Given this list of marker genes Dysf, Ppl, Hmgb1, F9, Tsku, Gata1, Rap2b, Ccn1, P2ry12, Hrg, Cd9, Scrib, Mfsd2b, Rreb1, Cd151, Prrg2 (NCBI Gene Id 70039), Anxa5, Gsdmd, Tor1a, Apoh, Duox2, Emilin1, Smad3, Fgl2, Insl3, Enpp4, Ccn4, Smoc2, Serpinf2, Papss2, Plek (NCBI Gene Id 69998), Mmrn1, Msx2, Pdcd10, Cd109, Prdx2, Tfpi2, Tmem97, Tfpi, Pdia3, Vtn, Tpm1, Gp1bb, Srsf6, Fermt1 (NCBI Gene Id 241639), Cldn1, Ext1, Clec7a, Epb41l4b, Gas6, Rhoa, Il1a, Pik3cb, Adra2a, Krt6a, Ddr2, Chmp7, F11r, Fntb, Gp1ba, Adra2b, Flna, Anxa1, Vil1, Plpp3, Hps1, Arhgef19, Lnpk, F12, Macf1, Pten, Fgl1, Mpig6b, Pecam1, Cxcr4, F11, Serpina10, Serpine1, Pdgfb, Gna13, Adamts18 (NCBI Gene Id 208936), Tspan8, Bloc1s6, Gp5, Ppara, Adipor2, Psg23, Fundc2, F10 (NCBI Gene Id 14058), Prrg1, Ppia, Gata4, Fgg, Fermt2, Kank1, Angptl1, Il6ra, Plau, Mtor, Vegfb, Hps4, Prss56, Ins2, Htr2a, Vangl2, Chmp4c, Jaml, Gnas (NCBI Gene Id 78290), Cd44, Cfh, Chmp3, Chmp1a, Fer1l5, Ppard, Ajuba, Chmp2b, Xbp1, Gnaq, Dag1, Fgf10, Celsr1, F5, Slc6a4 (solute carrier family 6 (neurotransmitter transporter, serotonin), member 4), Prkce, Chmp2a, Arl8b, F2rl2, Cnn2, Nf1, Emilin2, Mmp12, Ptk2, Smpd1, Igf1, Phldb2, Ubash3a, Vps4b, Chmp5, Thbd, Col3a1, Pdia2, Prrg4, Fcer1g, Trim72, Mrtfa (myocardin related transcription factor A), Fga, Tyro3, F13a1, Eng, Sdc4, Cldn13, Lrg1, Coro1b, Ccm2l, Plaur, S100a10, Hmox1, Dsp, Grhl3, Pros1 (protein S (alpha)), Syt11, Syt7, F2r, Chmp6, Map3k1, Bnc1, Ins1 (insulin I), Evl, Ptprj, Myh10, Mertk, Comp, Arhgap35, Ajap1, Cd36, Cdkn1a, Gpx1, Myh9, Hnf4a, Entpd2, Hgfac, Eppk1 (epiplakin 1), Mia3, Pdpn, Cpb2, Selp, Pdia4, Fbln1, Foxc2, Cav3, Tspan9, Cav1, Fgfr1op2, Cldn19, Foxa2, Casp7, Angptl4, Casp1, Mylk, Timp1, Wnt7a, Wnt3a, Alox15, Drd5, Plet1, Stxbp1, Ctsg, Angptl6, Hps5, Hras, Lrrc25, Itgb1, Gata2, Prkcd, Sytl4, Pard3, Angptl7, Rab3a, Tbxa2r, Cx3cl1, F8 (coagulation factor VIII), Nog, Vegfa, Vwf, Erbb2, Proc, Fgb, Prkg1, Rhoc, Ceacam1, Gpr4 (G protein-coupled receptor 4), S100a9, Dmtn, Axl, Prrg3, Srf, Stard13, Svep1, BC004004, Itga5, Cela2a, Fn1, Kng2, Evpl, Hbegf, Serping1 (serine (or cysteine) peptidase inhibitor, clade G, member 1), Nfe2l2, Dst, P2rx1, Ephb2, Ndnf, Muc16, Angpt2, Itgb5, F2, Ddr1, Cd40lg, Tec, Chmp4b, Entpd1, Bloc1s4, Clasp1, Ptpn6, Wnt5a, Acvrl1, Reg3a, Tpsab1, Itgav, Ptger4, Scnn1g, Pip5k1c, Notch2, Itgb3, Dcbld2, Crk, Pdia6, Cadm4, F13b, Kdr, Wfdc1, Yap1, Carmil2, Myoz1, Serpind1, Scnn1b, Fgf2, Arfgef1, Rasa3, Hif1a, Prf1, Angpt1, Mcam, Nbeal2, Lyn, Anxa8, Ccl2, Jak2, Lilrb4a, Tafa5, F2rl1, Plat, Gp9, Alox5 (NCBI Gene Id 232336), Plec, Slc11a1, Lyst, Pdgfa, Ubash3b, Nfatc1, Wnt4, Clasp2, Cask, Arhgap24, Fkbp10, Ano5, Aqp1, Fzd6, Nlrp6, Slc7a11, Tlr4, Anxa2, Shh, Pou2f3, Odam, Angptl2, Stxbp3, Col5a1, Tmprss6, P2ry1, Tubb1, Cldn4, Gzmb, Fermt3, Angpt4, Pf4, Rab27a, Duox1, Pear1, Ccr2, F3, Adra2c, Vkorc1, Nrg1, Nrp1, Serpinc1, Fzd7, Il6, Cxadr, Tnfrsf12a, Prkca, Itpr3, Apoe, Cd34, Actg1, Dtnbp1, Myof, Tspan32, Ptk7, Pak1, Slc12a2, Hps6, St3gal4, Snai2, Klkb1, Bloc1s3, Serpine2, Tgfb2, Fgf1, Pdgfra, C1qtnf1, Gla, Ano6, Elk3, Kng1, Adamts13, B4galt1, Prkcq, Reg3g, Adtrp, Pparg, Npr2, Tnf, Chmp1b2, Syk, Plg, Sh2b3, Hpse, Gp6, Prcp, Tmx1, Alox12, Proz, C1galt1c1, Clec10a, Thbs1, Cldn3, Vps33b, Procr, F7, Vps4a, Itgb6, Cflar, Treml1, Tmeff2, Ap3b1, F2rl3, Slc4a1 (NCBI Gene Id 20533), Pla2g4a, Chmp1b, here is a description of the gene set: Mouse Gene Set: GOBP_WOUND_HEALING The series of events that restore integrity to a damaged tissue, following an injury. species: Mus musculus